Given this list of marker genes OPRD1, SLC4A4, RND3, YTHDC1, RBM41, ALDH1A2, EPSTI1, OCA2, XPO1, ARF4, INO80D, LRG1, TAF15, AP1M2, MALT1, PDCD10, ELOVL7, APTX, SYT15, RBM25, SGMS2, CCNL1, SLC14A2, SPEF2, SPINK4, ANK2, GTF3C3, MACC1, CSF2RB, SRSF3, STK19 (serine/threonine kinase 19), TRIP10, SERPINI1, UBE2D1, NAA16, NLGN2, ZFP62, FRY, COL4A1, NPTN, LRTM1, TKTL1, PRLHR (NCBI Gene Id 9347), NFKB2, DDX5, SMARCE1, IL10RB, ZBTB5, ARFGEF1, URAD, PTK6, PAM, MIR155, PTPRO, UBR5, CHD9, P4HA3, DCUN1D1, LPP, TMEM184B, MIR142, TRIOBP, PTPN2, SMNDC1, GRAP2 (NCBI Gene Id 9402), TM4SF1, SVEP1, APOOL, ASB13, A2M, GYPA, GGCT (NCBI Gene Id 79017), ATP6V1B1, UBE2F, NR6A1, MIR130B, PJA2, CR1L, CTNNB1 (catenin beta 1), NMRK1, ZFAND5, HTR1A, RELB, DNAJB1, SLC35G3, SNRNP35, RC3H2, PDE10A, ENOX2, GLIS3, GPR52, RABGAP1L (NCBI Gene Id 9910), BIRC3, TMEM168, SDCBP, NMI, CLEC2D, CPNE3, FBXO40, GHSR, NUPR1, OSBPL5, ETNK2, BAIAP2L1, PUS10, WDR27, TNFRSF1A, ATP6V1D, ST6GALNAC1, MIR598, GFPT2, RAB22A, ZC3H12D, GNA13, TUBB2B, PPA1, MRE11, STAT6, HHIPL2, AKAP6, PCGF3, YME1L1, KDM5C, CLSTN3, TAF13, KBTBD13, WNK1, TRAF4, CRLF2, ECE2, APOBEC1, PRDM6, GNG7, CRKL, ASB16, ALDH1B1, RNF39, TRIB1, IL3RA, PURG, SOX21, FCER1G, APP, SLC25A25, LCOR (ligand dependent nuclear receptor corepressor), MIR149, DUSP16, PDP2, NAT14, IL21R, HPCAL4, NOCT, SEMA4A, EXT1, CHD2, PADI4, PLEK2, PAX9, NDN, SNX10, SCAPER, HNRNPH2, ZP2, TRPC1, SCIN, here is a description of the gene set: species: Homo sapiens Pioglitazone treatment of CD4+FoxP3- T cells transduced with Pparg and Foxp3 up-regulated a set of genes whose products have been implicated in lipid metabolism pathways. To verify the specificity of this treatment, we performed microarray analysis on Foxp3+Pparg1-transduced CD4+FoxP3- T cells after treatment with other PPARg agonists such as Rosiglitazone (TZD) and GW1929 (non-TZD). from publication Cipolletta D, Feuerer M, Li A, Kamei N, Lee J, Shoelson SE, Benoist C, Mathis D (PMID 22722857) Genes down-regulated in CD4 T cells treated with rosiglitazone and over-expressing: FOXP3 and PPARg1 isoform of PPARG versus FOXP3 and PPARg2 isoform of PPARG. Human Gene Set: GSE37534_PIOGLITAZONE_VS_ROSIGLITAZONE_TREATED_CD4_TCELL_PPARG1_FOXP3_TRANSDUCED_DN